Given this list of marker genes RNU6-812P, RNU6-827P, CTNNA2-AS1, MTND4P25, CYCSP6, LRRTM4-AS1, GNA13P1, REG1CP, RNA5SP98, MTND5P27, ENSG00000229494, RPL38P2 (NCBI Gene Id 100129991), MIR4264, GAPDHP57, REG3G, HK2, RNA5SP99, REG1B, MIR5000, MRPL19, ENSG00000238410, ENSG00000270571, RNU6-561P, SUCLA2P2, LINC01291, USP21P2, MTCYBP7, GCFC2, RBX1P1, RN7SL201P (NCBI Gene Id 106481830), RBM7P1, LRRTM4, RN7SKP164, DHFRP3, TACR1, POLE4, LINC01815, RN7SKP203, LINC01851, LYARP1, MTND6P7, CHMP4AP1, RNU6-685P, LRRTM1, EVA1A, EVA1A-AS, HK2-DT (NCBI Gene Id 118568819), PNPP1 (NCBI Gene Id 652561), MIR8080, REG1A, ANKRD11P1, CTNNA2, ENSG00000221638, SUPT4H1P1, REG3A, here is a description of the gene set: Human Gene Set: chr2p12 studied in species Homo sapiens